Given this list of marker genes ARHGEF12, TM4SF1, ALDH1A2, CRHBP, SOX4, CSF1, ARG2, NEFH, HPGDS, HSPB1, QPRT, EPS8, GDF15, UCHL1, PPFIBP1, HOMER3, NAP1L1, CYP1A1 (NCBI Gene Id 1543), TFPI, DUSP6, CH25H, here is a description of the gene set: Genes up-regulated by RUNX1-RUNX1T1 fusion protein in normal hematopoietic progenitors; their expression was sustained in subsequently developing monocytes. species: Homo sapiens from publication Tonks A, Pearn L, Musson M, Gilkes A, Mills KI, Burnett AK, Darley RL (PMID 17898786) The t(8;21)(q22;q22) occurs frequently in acute myelogenous leukaemia and gives rise to the transcription factor fusion protein, RUNX1-RUNX1T1 (also known as AML1-ETO). To identify the genes dysregulated by the aberrant transcriptional activity of RUNX1-RUNX1T1, we used microarrays to determine the effect of this mutation on gene expression in human progenitor cells and during subsequent development. Gene signatures of these developmental subsets were very dissimilar indicating that effects of RUNX1-RUNX1T1 are highly context dependent. We focused on gene changes associated with the granulocytic lineage and identified a clinically relevant subset of these by comparison with 235 leukaemia patient transcriptional signatures. We confirmed the overexpression of a number of significant genes (Sox4, IL-17BR, CD200 and gamma-catenin). Further, we show that overexpression of CD200 and gamma-catenin is also associated with the inv(16) abnormality which like RUNX1-RUNX1T1 disrupts core binding factor activity. We investigated the functional significance of CD200 and gamma-catenin overexpression in normal human progenitor cells. The effect of IL17 on growth was also assessed. Individually, none of these changes were sufficient to recapitulate the effects of RUNX1-RUNX1T1 on normal development. These data provide the most comprehensive and pertinent assessment of the effect of RUNX1-RUNX1T1 on gene expression and demonstrate the highly context-dependent effects of this fusion gene. Human Gene Set: TONKS_TARGETS_OF_RUNX1_RUNX1T1_FUSION_SUSTAINED_IN_MONOCYTE_UP